Given this list of marker genes RNU4-2, DDX23, EFTUD2, PRPF8, PRPF4 (NCBI Gene Id 9128), LSM2, SNRNP27, SNRPB (NCBI Gene Id 6628), RBM42 (RNA binding motif protein 42), TXNL4A, SNRNP200, LSM7, RNU6-7, RNU6-1, USP39, RNU5A-1, LSM4, RNU6-9 (RNA, U6 small nuclear 9), CD2BP2, LSM3 (NCBI Gene Id 27258), RNU4-1, RNU5B-1, PRPF3, SNRPE, SART3, RNU5E-1, LSM8 (LSM8 homolog, U6 small nuclear RNA associated), SNRPGP15, SNRPN, LSM6, PRPF18, SART1, PPIH, TXNL4B, SNRPF, RNU5D-1, LSM5, SNRPG (NCBI Gene Id 6637), SNRPD1, SNU13, SNRPD2, PRPF6, SNRPA, SNRPD3, RNU5F-1, ZMAT2, PRPF31 (NCBI Gene Id 6106), SNRNP40, here is a description of the gene set: Human Gene Set: GOCC_SPLICEOSOMAL_TRI_SNRNP_COMPLEX studied in species Homo sapiens A spliceosomal snRNP complex that is formed by the association of the U4/U6 (or U4atac/U6atac) snRNP with the U5 snRNP.